Given this list of marker genes Trp73, P2ry2, Ptger4, Tifab, Wnk4, Atg7, Egfr, Nkx2-3, Wnk3, Copa, Vamp8, Nr1h3, Sct, Mmp13, Neurog1, Slc4a9, Aqp5, Map1lc3b, Prkce (protein kinase C, epsilon), Aqp4, Tac4, Kcnma1, Wnk1, Cyba, Stk39, Htr4, Atg5 (NCBI Gene Id 97669), Sytl2, Slc4a5, Madd, Fgf10, Chrm3, Nr1h2 (NCBI Gene Id 381996), Traf3ip2, Gja1, Enpp1, Cel, Oprk1, Ada, Fosl2, Adora1, Ano1, Trpc1, Negr1, Celsr2, Chrm1, Aqp1, Npr3, Muc2, Alox12b, Adora3, Prickle1, Kcnn4, Agr2, Scnn1b, Nlrp6, Ppp3ca, here is a description of the gene set: Mouse Gene Set: GOBP_SECRETION_BY_TISSUE The controlled release of a substance by a tissue. studied in species Mus musculus